The following is a description of a gene set: species: Mus musculus from publication Yevshin I, Sharipov R, Kolmykov S, Kondrakhin Y, Kolpakov F (PMID 30445619) Mouse Gene Set: HOXD13_TARGET_GENES Genes containing one or more binding sites for (Hoxd13) in their promoter regions (TSS -1000,+100 bp) as identified by GTRD version 20.06 ChIP-seq harmonization., and this is the list of marker genes: Tbl2, Nfkb1, Etv1, Lins1, Phc2, Arhgef17, Maco1, Fgf9, S100pbp, D830032E09Rik (RIKEN cDNA D830032E09 gene), Dop1b, Arid4a, AU020206, Gm11772, Abca8b, Pde4d, Mir361, Hnrnph1, Laptm4b, Jmjd1c, Fam83d, Fos, Sox11, Slc25a17, Tnrc18, Slc1a2, Stard10, Septin11, Ppm1k, Cdrt4os1 (CMT1A duplicated region transcript 4, opposite strand 1), Junb, Mir669n, Hoxd9, Ppp1r13l, Gm13179, A130014A01Rik, Fry, Btbd7 (BTB domain containing 7), Pbk, Efnb2, Ncoa4, Endou, Reln, Zfp62, Gtf2b, Hoxa7, Ranbp9, Cdkl3, Hdac5, Rab11b, Crebl2, 1110002J07Rik, Ccdc30, Crebzf, Ctdspl2, Dusp5, Dppa1, Pick1, Stam, Ass1, Smpd5 (NCBI Gene Id 100503915), Hoxb6, Ak1, Rrm2, Tsku, Bckdk, Mindy4, Eps15l1, Foxp1, Sting1, Spsb4, Zfp64, Sdcbp, Steep1, Ier3ip1, Pfn1, Cyth1, Dhrs3 (NCBI Gene Id 20148), Gm15927, Tnrc6a, Prpf38a, Pbx3, Kmt5c, Arhgap28, Lta4h, Ralgapa2, Ostc, Sertad2 (NCBI Gene Id 58172), AW822252 (NCBI Gene Id 331578), Hspb8, Hexim1, Hes1, Thsd4, Gpatch11, Gm20324, Pde4b (phosphodiesterase 4B, cAMP specific), Rbm5, Hoxc6, Sema3c, Ergic1, Srf, Lats2, Hal, Snord43 (small nucleolar RNA, C/D box 43), Zfp260, Rhd, Cracd, Irgq, Zfp944, Setdb1, Vamp1, Erg, Dennd1b, 2900052L18Rik, Axin2, Fam185a, Dhx35, Gm22031, Rnf187, Spag9, Has2, 2600014E21Rik, Gss, Emx2os, Gm17494, Tmem245, Ktn1, Rpf2, Tomm7, Rasgef1b, Lrrc14, Gm8307, Ahcyl2, Snord42b, Pcdh18, 4732465J04Rik, Apc2, Gm12689, Sox6, Calm2, Sp1, Lrr1, Farp2, Gm13652, Mpp2, Ctdspl, Nfatc2, 1700008O03Rik, 2810433D01Rik, Asf1b, Mir760, Ppp6r3, Vax2, Rab5b, Gid4, Gdf11, Fbxo32, Rnd3, Per1, Snrpb, Lmo1, Tufm, Col9a1 (NCBI Gene Id 12839), Caps2, Unc13a, Rbfox3, 5730419F03Rik, Wfikkn2, Cecr2, Serpinb13, Trip4, Gm15575, Gm10544, N4bp2l2, Arhgap11a, Prdm11, Lmcd1, Lcn6, Gm11205, Nabp2, Brf2, Igf2r, Chaf1a, P4ha2, 5730596B20Rik, Gm15489, Gm13840, Elovl6, Proser1, Yipf5, Sox2, Faap24, Csf1, A730013G03Rik, Kdm5c, Tdrkh, Rpl18a, Pde9a, Gpr3, Hyi, Hoxa9, Med13, Gm15050, Kpna6, Slc15a4, Fzd10, Asb7, Wnt5a, Tmem138, Evx1os, C8g, Atoh1, Uts2b, Amdhd2, Pgam1, Gm5981, Rnf4, Slirp, Krt32, Rhobtb1, Etfb, Gm14461, Kif9, Sap18, Mia2, Larp1 (NCBI Gene Id 73158), Zkscan5 (NCBI Gene Id 22757), Fam90a1b, Gm15997, Cryzl1, Mir22hg, Tanc1, Wasf2, Klhl14, Wdr59, Hoxd4, Ccdc192, Mcm3, Rnf26, Cic, Lrrc17, Gcat, Ssbp3, Eif4h, Pcx, Gm26703, Nup93, Recql4, Tdp1, H4c16, Hoxaas3, Gm29200, Rassf9, Dclre1a, 1810007C17Rik, Smarcal1, H2ax, Uggt1, Ctnnb1, Zfp28, Mcub, Rab11fip1, Slit3, Vasp, Cdc6, Mir7687, Mrtfa, Utp3, Asns, Gng8, 9430024E24Rik, Nvl, Lmo2, BB218582, Prrx1, Nuak2, Mtmr10, Irs2, Ido2, Gm15478, Cdc25a, Tm9sf4, Smarca2, Pigp, Naa50, Camkmt, Psd3, Gins1, Poll, Gm16118, Gm21992, Phf5a, Sdk2, Farsb, Mir3074-1, Gm36211, Kank1, Tnc, Gm11690, Ccng2 (NCBI Gene Id 12452), 5031415H12Rik, Ice2, Dlgap5, Usp5, Sema3a, Abhd18, Jmjd8, Cfap44, Inava, Nhsl1, Riiad1, Mfsd6 (major facilitator superfamily domain containing 6), Gm9578, Slc16a6, Tlx3, Gm20052, Ccz1, Gm34727, Rpl32, Usp10, Taf5, Hoxa11os, Nid2, Pnrc1, Tspan9, Fv1, Snora7a, Casp8ap2, 2310001H17Rik, Cobll1, Cited1, Dnaaf3, Cdc42ep4, Efcab11, H4c2, Larp7, Med13l, Gk5 (NCBI Gene Id 320574), Nck2, Gm13421, H1f3, Gm35986, Defb11, Ambra1, G430095P16Rik, Fscn1, Arhgap26, Gm13001, Mef2c, Orc1, Plekhm3, Foxo6, Vrk1, Ganab, Chchd3, Mid1ip1 (Mid1 interacting protein 1 (gastrulation specific G12-like (zebrafish))), Kazn, Meis2, Tex14 (NCBI Gene Id 97747), Vps36, Itga6, Gmfb, Vax2os, Sdk1, Nat8f1, Aco2, Gm8330, Snx1, Ralgps2, Hsph1, Pierce2, Aurkaip1, Gm12289 (NCBI Gene Id 102631925), Hexim2, Atpaf2, Etv4 (NCBI Gene Id 217208), Ftl1, Ash2l, Heatr5b, 5031434O11Rik, Etv5, Hotairm1, Hoxa3, Cxcl10, Tmco6, Galnt5, Plekhg2, 2210011K15Rik, Gm11832, Adamts10, 1700007F19Rik, 4930527B05Rik, Alg9, Myo1h, Gm16070, Nudt1, Ogt, Gsk3b, Kdm5b, Shb (NCBI Gene Id 230126), U2af2, Ube2s, Arid1b, Nrxn1, Gm17970, Pdlim4, Inpp4b, Tbcd, Tpra1, Atg10, Timm13, Cdc40, Cacfd1, Itpripl2, Ndrg1, C130026L21Rik, Srpk2, Inppl1, Slc4a2, 4921539H07Rik, Ephb4, 1700016A09Rik, 1700040D17Rik, Flrt2 (NCBI Gene Id 399558), Ptch1, Gm30946, Iqschfp (NCBI Gene Id 100505386), Fam216a, Krt39, Fam240b, Tssc4, Wasf1, Schip1, Scara5, C87436, Abhd17a, Mafa, Dtnb (dystrobrevin, beta), Fgf7, Lockd, Atl2, Rab3a, Tcta, Lsm14b, Sec22a, Snap25, Kmt5a, Qdpr, Akap11, Abhd10, Hadh, Selenop, Map2k6, S1pr1, Xab2, Gm15644, Gm19774, Mecomos, Wdr18, Zfand3, Gm3235, Triobp, E030025P04Rik, Zmiz1, Cdh2, Ypel1, Cenpm, D030040B21Rik, Pik3ca, Gm11528, Fmo6, Mmp9, Wdr95, Ldlrap1, Ano7, Pik3ip1, Gabpb2, Zbtb10 (NCBI Gene Id 99802, zinc finger and BTB domain containing 10), F8a, Smad3 (NCBI Gene Id 17127), Etv6, Pdgfa, Fbxw5, Urm1, Mir6936, Tnks1bp1, Ramp2, Sema6d, Mir3077, Ccdc174 (coiled-coil domain containing 174), Slc1a4, Rbm25, Gatad2b, Gm40304, Rpl23a, 4930458A03Rik, Gm13268, Atp6v0d1, Kctd18, Eapp, Ninl, Trappc5, Rcc2, Slc35a2, Mir615, Mir8098, Dhx33, Kat6b, Shisa7, Tenm3, Atxn7l1, Taf6, Kdm3a, Atp5me, Zfp36l1, Rbm15, Katna1, Akt1s1, Dad1, Rgmb, Bcl10, Pdgfra, Prepl, Tprkb, Tgif1, Polr1g, Gm19102, Casp4 (caspase 4, apoptosis-related cysteine peptidase), Tti2, Atp6v1a, Gm4861, Osbpl1a, Zfp1, Epb41, Mta2, Gtpbp8, Ttpa, Klhl21, Alkbh1, Zic2, Ptk2, Plpp3, Gm14858, Cep89, Itgb5, Rit2, Zmynd12, Hand2, Nudcd2, Cpsf4l, Cars1, Mir155hg, Igbp1, Rbm14, Nadk2, Gjc1, Thra, Yars1, Nkx1-2, Skida1 (NCBI Gene Id 99443), AU015336, Daw1, Arrdc4, Bahcc1, Nanp, Gsto1, Lrrtm4, Dusp6, Khdrbs1, Srrm1, Trim23, Gm11679, H2az2, Svopl, 1700113A16Rik, Lsm5, C230014O12Rik, Atg4d, Csnk1g1, Mcl1, Ncor2, Sdc1, Igf2bp3, Prg2, Anapc15, Gm4755, 4930532G15Rik, Lmna, Ccpg1, Phb1, Atp6v1e2, Tent5b, Nav2, Hmmr, Eloc, Rab18, Senp2, Gm17057, Hoxa10, Hddc3, Slc30a7, Cacnb2, Usp39, Drosha, Ulk4, Cttnbp2, Zfp36, Cep131, Gm25541, Tulp3, Atg9b, 2610307P16Rik, 2610035D17Rik, Gnas, Msrb3, Mgme1, Mrpl15, 1700003D09Rik, Miat, Cyb561a3, Mir199a-2, Pik3r3, Fzd2, Fgd4, Clhc1, 3110056K07Rik, 4930439D14Rik, Hoxa1, Zfp438, D930007P13Rik, Miip, Cdk12, Rtraf, Serinc5, 9030622O22Rik, 4921522P10Rik, Nfkbia, Pcm1, Jazf1, Maml3, Trim41, Gpn3, Zfhx4, Akt2, Nsun4, Hoxa11, Hoxb8, Vcp, Dpcd, 1700030C12Rik (RIKEN cDNA 1700030C12 gene), Smad6, Mir707, G630022F23Rik, Fut10, H2ac5-ps, Taf11, Nhlrc3, Hoxd13, Trappc13, Sox4, Ppm1h, Mir7238, Elp6, Grhl2, Acp6, Rps17, Cdca7, Csnk1a1, Mdga1, Stard3, Dock3, Gcnt2, Ppp5c, Dysf, Tbx18, Mycn, Irf8, H3c7, Ppat, Bach2, Gm38250, Pspc1, Ticrr, Rpl3, Ccdc85c, Klf7, Gja1, Gpr19, Csrp2, Wdfy2, Gpx7, Arsg, Rhoa, En2, Tbc1d17, Ufsp1, Psma8, Gm15969, Serhl, Emx2, 4933401H06Rik, Srsf7, Mknk1, Plxdc2, Zbtb5, Pdlim3, 4933440N22Rik, Bcas3os1, Phaf1, Mageb3, Cnpy4, Casz1, Itsn1, Msx2, Dusp4, Gm26791, Hmgn2, Ilf2, Per2, Gm30292, Tcp11l2, Pet100, Vgf, Gm11217, Tut1 (terminal uridylyl transferase 1, U6 snRNA-specific), Rgs4, Ephb3, Ccnd2, Gm9826, Fryl, Serinc4 (NCBI Gene Id 574418), Ptpa (protein phosphatase 2 protein activator), Akirin2, Vps45, Krt87 (keratin 87), Cxxc4, Nbea, Hoxd3, Bsdc1, Ppard, Klhl18, Gm8865, Pcsk5, Tenm4, Wbp1, Sash1, Hypk, Abhd4, Gm33651, Phf21b, Meox1, Cuedc1 (NCBI Gene Id 70393), 1700055D18Rik, Gtf2h4, Gm9889, Zfp423, Rnf122, Apoo, Phip, Wdr6 (NCBI Gene Id 83669), Trim24, Ddb2, Gm20587, Pcnx1, 2610027K06Rik, Wsb2, Gm7290, Sorbs2, Tbx5, Dnaaf9, Tspyl3, A330035P11Rik, Homer3, Gm7308, Snord13, Mmp17, Rps27a, Gm6471, Cstpp1, Gm32996, Cacna2d1, Gm18303, Gm11228, Gm36548, Nckap5, Rpl41, Ssbp1, Gm10644, Sirt7, Ranbp6, Nfxl1, Evi5l, Fbxo47, Prtg, Tbx2, Tpd52, Qars1, Twist1, Pla2g4a, Cdca3, Tbc1d10b, Gtpbp2, Abcb7, 2610035F20Rik, Ppcs, Ift27, Rbpms, Plk1, Tspan18, Adgrl1, Neurl4, Aph1a, Phyhipl, Ahsa2, Evx2, Gm10634, Zfp512b, Iqcj, Aldh1l1, Exoc4, Aicda, Zfp945, Ccdc61, Rbm4, Ssbp2, Ap2m1, Hydin, Gm13990, Lasp1, Krt35, Rbm19, Ctdsp2, 2810408A11Rik, Abca1, Ctdp1 (NCBI Gene Id 67655), Dnajb5, Ttc39d, Cltc (NCBI Gene Id 97762), Ankrd10, Sec16b, Cpa2, Chac2 (NCBI Gene Id 68044), Cnih4, Dnm3os, Spry4, Bmpr1b, Mad1l1, Nono, Tcerg1 (transcription elongation regulator 1 (CA150)), Gm15579, Cnot3, Reep3, Plekha3, Slc25a25, Gm13790, Zfp354b, Lmo7, Zbed5